Given this list of marker genes TAF11L2, MED23, WNT10B, TAF11L8, TAF6L, TAF11L12, MED15, MED26, MED16, TAF11L4, MED20, GTF2A1, TAF11L3, ESR1, MED30, CREB1, CAND1, TAF1L, TAF5, MED9, TAF13, TAF10, PSMC6, TAF7L, MED10, TAF3, TAF11L14, TAF11L10, TBP, TAF2, DR1, TAF11L13, TAF11, MED7, MED18, MED31, MED28, HMGB1, TAF11L6, GTF2A2, MED27, TAF4B, MED17, MED6, MED21, MED29, TAF11L11, MED25, MED4 (NCBI Gene Id 51757), TAF11L9, GTF2B, MED14, MED22, TAF1, TAF12, TAF9, MED24, MED8, THRA, TAF4, TP53, TAF7, TAF8, MED11, TAF11L7, TAF6, MED19, MED1, here is a description of the gene set: The formation of a large multiprotein-DNA complex that self-assembles on gene promoter through the sequential recruitment of the general initiation factors that compose the preinitiation complex (PIC) (which may include TFIIA, TFIIB, TFIID, TFIIE, TFIIF, and TFIIH complexes). The PIC engages RNA polymerase II on its DNA template strand and sparks polymerization of the first few RNA nucleotides of the nascent transcript, of which 8 are base-paired with the DNA template within a DNA bubble. PIC assembly may result in a pause step, which marks the end of the PIC assembly and may be followed by promoter clearance (exact synonym: promoter escape). For RNA polymerase II PIC assembly is preceded by the formation of a nucleosome-free region that allows the transcription machinery to access the promoter DNA. Human Gene Set: GOBP_RNA_POLYMERASE_II_PREINITIATION_COMPLEX_ASSEMBLY species: Homo sapiens